Given this list of marker genes PTH1R, TSC1, MT-TW, YY1, CLDN10, MT-ATP8, HADHA, MT-CO1, KMT2D, SEC24C, PIGT, MT-ND1, CDC73, VDR, RRM2B, LIG4, AP2S1, TSC2, GP1BB, TBX2, TBCE, COMT, GATA3, AIRE, GALNT3, ARMC5, MPV17, HADHB, FLCN, SLC12A1, KL, MT-ND6, CLCNKB, KCNJ10, MT-TH, PHEX, GNAS, ANKH, MT-TF, FOXI1, TBX1, JMJD1C, CA2, COL4A5, GNAS-AS1, UFD1, ATP7B, RET, ESS2, GNA11, PRMT7, DGCR2, CHD7, NSUN2, NF1, HIRA, FAM111A, MT-CO2, PTH, CDKN2B, IRX5, CDKN1A, CDKN1B, KDM1A (NCBI Gene Id 23028), MT-ND4, MT-TL1, ACTG2, MT-TS2, ZFX, KDM6A, IDH1, TRPV6, SLC26A4, ARVCF, GCM2, MEN1, STX16, HBB, CYP27B1, PTEN, DGCR8, NKX2-1, IFNG, CYP2R1 (cytochrome P450 family 2 subfamily R member 1), MT-ND5, PLEKHM1, MT-TQ, DGCR6, OCRL, RREB1, IDH2, SLC12A3, CASR, MT-CO3, PRDM10, CDKN2C, SLC4A2, here is a description of the gene set: Human Gene Set: HP_ABNORMALITY_OF_THE_PARATHYROID_GLAND Abnormality of the parathyroid gland studied in species Homo sapiens An abnormality of the parathyroid gland.